Given this list of marker genes Fat4, Zeb2, Nr3c1, Dync1i2, Zfp580, here is a description of the gene set: Mouse Gene Set: MIR_6347 species: Mus musculus from publication Chen Y, Wang X (PMID 31504780) Genes predicted to be targets of miRBase v22 microRNA mmu_miR_6347 in miRDB v6.0 with MirTarget v4 prediction scores > 80 (high confidence targets).